Given this list of marker genes XPO4, AIMP1 (NCBI Gene Id 9255), FERMT3, SRGAP3, RPS21, C18orf21, C3AR1, IPO11, LIN37, WNT8A, JCAD, PHC2, TEX261, RPL13, SLC38A9, EMC10, MAML2, DLGAP4, STK32C, DCSTAMP, NDUFAF5, PIEZO1, TICRR, RBM15B, IQSEC2, SRGAP1, H1-0, DPY30, LGALS1, CIBAR1, ZNF579, ADCK1, SERPINA3, APRT, PLPPR4, TRMU, CREB3L2, DTL, TOR1AIP2, COQ7, RTL5, CAPRIN2, IL6ST, SUOX, CDRT4, CDC7, HINT2, DENND1A, GPR183, PREP, PRSS54, BOD1L1, SMC5, SPTLC1, MTFR1L, RBPJL, SLC16A2, RABGAP1L, CD48, MYO9A, SOCS2, NDUFB11 (NADH:ubiquinone oxidoreductase subunit B11), ENTPD6, TMEM245, LSG1, SVEP1, RPL13A, HTR7, GALNT6, C4B, WDR74, SLC7A5, ATP10B, MRPL45, CHST13, CAMLG, RNF123, ADGRG6, CYFIP1, VPS41, FGFR1, RASSF4, SLCO2A1, ZNF3, SOD3, RGP1, LRBA, RPL14, PMS2, PRKCA, KRT79, GAS2L1, MAP3K20, DRG1, FHL2, FSCN1, ARL6, MYLK, DTWD1, RPL4, LAP3, ACVRL1, L3HYPDH, RASL10B, NCAPH2, CYGB (NCBI Gene Id 124510), SFTPD (surfactant protein D), LACC1, EXT2, RPL34, SOCS7, TBXAS1, SUV39H1, TPRKB, DLST, SERPINB9, SLC5A2, SKA2, C19orf47, EBNA1BP2, MAST2, TNIK, RPL27, TARS1, DPYSL2, RAB12, SRRT, BCL2, MEST, ERI1, MNX1, IGFBP7, BEX2, ASH2L, SH3KBP1, FAT3, SPAG6, B4GALT6, NAPB, TACC3, HELZ, PCYT1A, EIF4E3, THRAP3, ADGRF5, OPN1SW, SELENOW, SIGLEC10, CPSF2, CYB5R2 (cytochrome b5 reductase 2), ABL1, DPEP1, DEPP1, RPS4X, CPT2, PCCA, FBXO25, FKRP, KCNAB2, ANAPC5, HES1, STXBP5L, MAGED2, CCDC186, SNX19, NDUFB10, EPOR, ACP3, IL5RA, ZNF790, PRMT1, EIF3E, RCOR3 (NCBI Gene Id 55758), MIR99AHG, KRT84, LPIN1, ASPA, NCKIPSD, SPRY1, CTNNBL1, RPS18, CNIH1, ZNF329, CD81, GPC6, HEXB, BHMT2, MRGPRE, CLSTN1, LONP1, BTD, TTK, ZFP2, RAD23A, SNAP47, CBFB, ANKRD50, RAB6B, SGCE, here is a description of the gene set: Human Gene Set: GSE36392_TYPE_2_MYELOID_VS_EOSINOPHIL_IL25_TREATED_LUNG_UP Genes up-regulated in comparison of type 2 myeloid (T2M) cells treated with IL25 versus eosinophils treated with IL25. Many symptoms associated with allergic asthma result from the sequelae of type 2 inflammation. Interleukin (IL)-25 promotes type 2 inflammatory responses, and T2M cells represent an IL-4 and IL-13 producing granulocytic IL-25 responsive population. We used microarrays to characterize the gene expression profile of T2M cells, and compared T2M cells to other inflammatory subsets (eosinophils, neutrophils, and macrophages) in the lungs of mice with IL-25-induced pulmonary inflammation. from publication Petersen BC, Budelsky AL, Baptist AP, Schaller MA, Lukacs NW (PMID 22543263) species: Homo sapiens